Given this list of marker genes ANKDD1A, DHRS13, PON2, ENC1, MT1H, LPP, CRYL1, ABHD14B, RNF157 (NCBI Gene Id 114804), SNX29, ZFAND2A, SCRN1, ARRDC3, PDLIM2, GPR143, PGAP3 (post-GPI attachment to proteins phospholipase 3), MORC2-AS1, GABARAPL1, MT4, TSC22D3, ETHE1, UBASH3B (ubiquitin associated and SH3 domain containing B), PAN2, VAMP5, RNPEP, TMEM9 (NCBI Gene Id 51235), LDB2, R3HDM2, XPC, DUSP10 (NCBI Gene Id 11221), RBM38, IGBP1, ITGA4, CNBD2, FAM8A1, HAUS5, HEMK1, ZNF394, ZC3HAV1, DLL1, ENSG00000280119, CTSK, CD248, TMCC3, UBL4B, EPHA4, CGRRF1, TEX14, ACAP1, ETFB, TBC1D10A, DTD1, HOXD11, DSC1, STMN3, RAP1GAP2, MPPE1, C11orf21, BIN1, WDR27, SFXN5, XAGE3, TFDP2, RFX3, DPEP2, WDR13, GSE1, TPM2, FBXL16, SUSD3, ARRB2, PIEZO1, MAN2B2, CCNE1, PTP4A1, KCNA3, NDRG1, KHK, IQGAP2, LRP2BP, C4BPA, SAMHD1, CASP9, DIS3L2, IL10RA, DUSP1, SNN, FBXL12, FBXL20, SLC22A18, PIK3R5, ZNF438, SLC35G1, MTFR1L, FHIT, DIAPH2, PARP3, TRAM2, GSAP, LRRC37A2, HAR1A, COMMD9, CSRP1, THBS3, HAUS4, TCEA3, NPC2, SIK1, SH3PXD2A, TMEM256, ITGAM (integrin subunit alpha M), FAM111A, ENPP2, FLOT2, ALDOC, RBM33, FCGRT, KRT73, SUSD4, ITGB7, ITPRIP (inositol 1,4,5-trisphosphate receptor interacting protein), IRS2, G0S2, ZNF844, SLC9A9, TRABD2A, ADM, H1-10 (H1.10 linker histone), ATP2B1-AS1, SIGIRR, ZDHHC11, KLF4, TTN, CTPS2, CORO1B, UBE2Q2P13, PTPRM, ITGB2, LCOR, KCTD3, ERP27, TAMM41, ZNF731P, FES, GOLGA4-AS1, ST3GAL5, AREG, LLGL2, GARS1-DT, NUP210, SRGAP3, TRADD, VIPR1, VNN2, HABP4, SC5D, FAM13A-AS1, EFHC2, PCIF1, C1QTNF12, CD4, DNAJC4, PCNT, SSBP4, GJC2, ACSS2 (acyl-CoA synthetase short chain family member 2), SIAE, AK5, ZBTB20, GALNT12, S100A6, STK16, MT1X, DPPA5P4, DNAJB1, IL11RA, HEBP2, TJP2 (NCBI Gene Id 9414), TP53INP2, KLF7, EPHX2, PELI2 (pellino E3 ubiquitin protein ligase family member 2), ECHDC2, PSTK, GABBR1, BIN2, TAFAZZIN, SLC22A23, TOB1, MYO1G, TTLL5, REM2, here is a description of the gene set: Human Gene Set: GSE17974_0H_VS_4H_IN_VITRO_ACT_CD4_TCELL_UP The aim of this dataset was to study in detail the transcription kinetics initiated by cytokine IL-4 in early differentiation of Th2 cells. Genes up-regulated in comparison of untreated CD4 T cells at 0 h versus the untreated cells at 4 h. studied in species Homo sapiens from publication Elo LL, Järvenpää H, Tuomela S, Raghav S, Ahlfors H, Laurila K, Gupta B, Lund RJ, Tahvanainen J, Hawkins RD, Oresic M, Lähdesmäki H, Rasool O, Rao KV, Aittokallio T, Lahesmaa R (PMID 20620947)